Given this list of marker genes ZEB1, TMIGD1, NKX2-8, AQP11, CAV1 (NCBI Gene Id 857), NLRC3, MIR152 (NCBI Gene Id 406943), PPARG, MIR29C, IFT52, WNT10B, MIR29B1, PTPRK, PTPRM, MIR149, HSF1, MIR15B, MIR205, FLT1, EPPK1, ACVRL1, IFT74, AIMP1, CDK6, MIR132, IL26, MIR342, OVOL1, MIR30B, APOE, MIR410, ENG, IL12A, IL12B, DLG1, NF1, WNT5A, MIR92A1, MARVELD3, MIR22, RGCC, MMRN2, RAP1GAP (NCBI Gene Id 9676), MIR503, MAGED1, VDR, GDF5, EAF2, AR, STK11, MIR34A, ISL1, LIMS2, SCG2, BRCA2, B4GALT1, ATOH8, CDKN2A, NGFR, MIR26A1, CNMD (NCBI Gene Id 373170), RB1, STK4, MIR361, SYNJ2BP, MIR125B1, TNF, GDF2, KDF1, MIR329-1, DLL4, DAB2IP, MIR495, SULF1, MIR494, MIR146A, ALOX5, GATA3, GATA6, MIR497, FLCN, INTU, BMP4, CEACAM1, NKX3-1, SFRP2, MIR193A, PHOX2B, STAT1, ATP5F1A, EFNB2, CAV2, MIR129-1, EREG, NR2F2, MIR98 (NCBI Gene Id 407054), SERPINF1, KLF9, MIR222, DSC1, APOH, TNMD, KRT4, IFT172, GPC3, CDKN1C (cyclin dependent kinase inhibitor 1C), PHB2, MTSS1, MIR15A, PDX1, IFT80, CDKN2B, A4GNT, MIR24-1, TGFBR1, IRF6, DUSP10 (NCBI Gene Id 11221), IFT57, NOTCH1, SAV1, MIR21, CDKN1B, MIR181C, SNAI2, PRL, THBS1, CD109, MIR20B, SFN, SOX9, MCC, MIR2355, MIR487B, CDC73, FGFR2, TGFB2, SPARC, NUPR1, VASH1, CXCR3, WDR13, COL4A3, CASK (NCBI Gene Id 8573), TGFBR3, SFRP1, TINF2, HPN, MIR424, PPARD, B2M, WDR77, MEF2C, RUNX3, MIR16-1, MIR133B, MIR483, PDCD10, MIR492, PEX2, PAX6, PTCH1, KRIT1, CCL2, MIR30E, STK3, SLURP1, ATP5IF1, MED1, TGFB1, ROBO1, MIR126, DRD2, DAB2, NFIB, FBXW7, TRIM24, GHRL, here is a description of the gene set: Human Gene Set: GOBP_NEGATIVE_REGULATION_OF_EPITHELIAL_CELL_PROLIFERATION studied in species Homo sapiens Any process that stops, prevents or reduces the rate or extent of epithelial cell proliferation.